The following is a description of a gene set: Human Gene Set: KANG_DOXORUBICIN_RESISTANCE_DN from publication Kang HC, Kim IJ, Park JH, Shin Y, Ku JL, Jung MS, Yoo BC, Kim HK, Park JG (PMID 14734480) species: Homo sapiens PURPOSE: A major obstacle in chemotherapy is treatment failure due to anticancer drug resistance. The emergence of acquired resistance results from host factors and genetic or epigenetic changes in the cancer cells. The purpose of this study was to identify differentially expressed genes associated with acquisition of resistance in human gastric cancer cells. EXPERIMENTAL DESIGN: We performed global gene expression analysis in the acquired drug-resistant gastric cancer cell lines to the commonly used drugs 5-fluorouracil, doxorubicin, and cisplatin using Affymetrix HG-U133A microarray. The gene expression patterns of 10 chemoresistant gastric cancer cell lines were compared with those of four parent cell lines using fold-change and Wilcoxon's test for data analysis. RESULTS: We identified over genes differentially expressed in 5-fluorouracil-, cisplatin-, or doxorubicin-resistant gastric cancer cell lines. Our expression analysis also identified eight multidrug resistance candidate genes that were associated with resistance to two or more of the tested chemotherapeutic agents. Among these, midkine (MDK), a heparin-binding growth factor, was overexpressed in all drug-resistant cell lines, strongly suggesting that MDK might contribute to multidrug resistance in gastric cancer cells. CONCLUSIONS: Our investigation provides comprehensive gene information associated with acquired resistance to anticancer drugs in gastric cancer cells and a basis for additional functional studies. Genes down-regulated in gastric cancer cell lines: doxorubicin resistant vs sensitive., and this is the list of marker genes: TMEM106B, WASHC4, PTP4A2, SIKE1, RB1CC1, CRIM1 (NCBI Gene Id 51232), CLIC4, ASXL2, PCYOX1, NFAT5, ATP2B1, TBL1X, PSAT1, CEBPD, WWP1, NCOA3, NR1D2, TJP1, DESI2